Given this list of marker genes TMEM132B, AFF4, EEIG1, SINHCAF, CNOT6L, CHD3, SUFU, UBE2M, TMEM260, FUT8, SPRY2, ISLR, GTPBP1, GSTT2B, NEGR1, PTPN1, FBRS, CHST5, DGAT2, PLA2G6 (phospholipase A2 group VI), ARPC4, SMUG1, CHIA, CPEB3, TFB1M, MLIP, PCDH9, PLCB1, GYPB, SNW1, CDC42EP1, PPARD, TULP3, TANC2, DPY19L1, POU2F2, MITF, CDK19, here is a description of the gene set: Genes predicted to be targets of miRBase v22 microRNA hsa-miR-6743-5p in miRDB v6.0 with MirTarget v4 prediction scores > 80 (high confidence targets). from publication Chen Y, Wang X (PMID 31504780) Human Gene Set: MIR6743_5P species: Homo sapiens